The following is a description of a gene set: Immune cell-specific expression is one indication of the importance of a gene's role in the immune response. In order to identify such patterns, we set out to broadly profile gene expression in a variety of immune cells. Human Gene Set: GSE22886_IL2_VS_IL15_STIM_NKCELL_UP studied in species Homo sapiens from publication Abbas AR, Baldwin D, Ma Y, Ouyang W, Gurney A, Martin F, Fong S, van Lookeren Campagne M, Godowski P, Williams PM, Chan AC, Clark HF (PMID 15789058) Genes up-regulated in comparison of NK cells stimulated with IL2 at 16 h versus NK cells stimulated with IL15 at 16 h., and this is the list of marker genes: SPACA1, IL19, TRPM3, ARG2, SEC14L5, ITPR2, PNMA8A, BAAT, RARRES1, MS4A1, SYNGR4, SLC66A3, LAMA5, BACE2, PTPRZ1, HAVCR1, ASB4, TAOK2, CCKBR, IRX4, PLA2G1B, EGLN3, WASF3, TIAM2, UBOX5, NUDT13, SH3PXD2A, ABCA12, PMS2P1, POU4F3, IGLV6-57, PTN, TYRO3, IL1RAPL1, ING4, IL21 (NCBI Gene Id 59067), CDH20, RNF216, RIT2, PSRC1 (proline and serine rich coiled-coil 1), RANBP17, PCDHA6, SGK2, TPO (NCBI Gene Id 7173), CBLN1, DGKG, CHGB, C3orf36, ME1, AREG, MMP24, FXYD2, TAS2R7, PDE5A, CHP2, EPHB6, CCT8L2, LINC00837 (long intergenic non-protein coding RNA 837), PEG3, PCBP3, ZNF480, C1orf56, TFCP2L1, MYH1, TRDN, BEST2, GJB1, G6PC2, KLHL4, TMPRSS11E, DGCR5, VIP, KCNB1, B3GNT3, TCTN3, ALLC, RAPGEF5, BCKDHA, LPO, FKBP9, SENP3, DNAI4, FRAS1, SLC22A4, RNASEH2B, KATNIP, GARNL3, HTR1A, ETNK2, LDB2, ADAMTS7, CNTNAP3B, FMO6P, ESRP1, ITGB4, F2RL2, ADAM12, PDE1B, WAC, NME6, TLN2, OSR2, APOA4, OS9, GATM, ATP6V0A4, ASGR1, NEUROG2, A4GNT, KRT84, SLC2A2, H2BC10, POU1F1, KCNH4, C1S, TRPM8, SYT13, CT62, APP, MAPRE3, BCO1, RAB3D, SPTBN5, VSNL1, CASQ1, PSD3, INSRR, SOX1, FSCN2, KCNJ14 (NCBI Gene Id 3770), SAGE1, CREB5, LGALS13, THBS1, SLC2A9, PSORS1C2, PAX5, PAX2, CLIC5, MBTPS2, AGAP2, CHRNA9, EPPIN, TBX3, KRT31, C5AR2, SOX14, ALX3, CPZ, CAPN7 (NCBI Gene Id 26587), SLC13A1, SCAMP5, PLLP, OR6A2, MCCC2, EPHX1, GNAO1, RBM39, MLLT10, CHIA, CHRND, DCLK1, OR10H3, CD34, SLC39A2, THTPA, CHST1, TEK, KSR1, ADAMTS6, CNGB3, TAS2R16, SFRP1, COL5A2, SLCO2A1, MAP3K9, DSTYK, PCOLCE, CLDN10, ADRB3, STRADA, MPZL1, FAM174B, PCDHGB6, SEMA7A, NIPSNAP3B, SCG5, GUCY2C, SYT2, MAGEA8 (NCBI Gene Id 4107), ATP8B3, DGKE, IL20RA, PHF1, THBS2, ZNF536